Given this list of marker genes POR, BRD4, SMC1A, NIPBL, TWIST2, FIG4, FGFR2, CTCF, DVL3, ROR2, RIPK4, SETBP1, CDC45, GAD1, ORC1, CDC6, ORC4, RAD21, IRF6, ECEL1, GMNN, WNT5A, VAC14, B3GLCT, SMCHD1, RAB3GAP2, ORC6, CDT1, ESR2, PPP2R3C, TAF6, SLC25A24, TP63, SMC3, DVL1, FZD2, UBE3B, HDAC8, here is a description of the gene set: Undergrowth of the outer labia. Hypoplastic labia majora species: Homo sapiens Human Gene Set: HP_HYPOPLASTIC_LABIA_MAJORA